Given this list of marker genes PSMD6, VCP, UBC, SEM1, PSMD3, SHH, PSMB3, PSMB6, RPS27A, PSMD13, UBB, PSMA1, HHAT, PSMD2, PSMB7 (proteasome 20S subunit beta 7), PSMA4, SYVN1, SEL1L, DERL2, OS9, PSMD14, PSMB1, IHH, PSMD8, PSMB2, PSMD11, PSMC3, PSMD7, PSMA3, PSMA5, DHH, PSMA2, PSMC5, PSMA7, PSMC4, PSMC2, PSMD1, PSMA6, PSMB5, PSMC1, UBA52, PSMB4, PSMC6, ERLEC1, ADRM1, PSMD12, here is a description of the gene set: Hh signaling is required for a number of developmental processes, and mutations that disrupt the normal processing and biogenesis of Hh ligand can result in neonatal abnormalities. SHH is one of a number of genes that have been associated with the congenital disorder holoprosencephaly, which causes abnormalities in brain and craniofacial development. SHH variants associated with the condition affect the autocatalytic processing of the precursor and dramatically impair the production of the secreted active Hh-Np, abrogating signaling. Aberrant Hh signaling is also associated with gondal dysgenesis syndromes in which palmitoylation of DHH is abrogated by mutation of the acyltransferase HHAT. Reactome Pathway: Hh mutants abrogate ligand secretion species: Homo sapiens part of: Diseases of signal transduction by growth factor receptors and second messengers